The following is a description of a gene set: part of: Metabolism of vitamins and cofactors studied in species Homo sapiens Vitamins A, D, E, and K are classified as fat-soluble. Metabolic pathways by which dietary precursors of vitamins A and K are converted to active forms are annotated here. The conversion of 7-dehydrocholesterol is converted to active vitamin D is annotated as part of metabolism of steroids. (Vitamin E (tocopherol) is available in active form from the diet.) Reactome Pathway: Metabolism of fat-soluble vitamins, and this is the list of marker genes: RBP1, RBP4, APOC3, GPIHBP1, TTR, AGRN, UBIAD1, SDC3, APOB, LRP10, GPC1, PNLIP, SDC2, LRP12, LRP1, APOM (apolipoprotein M), APOE, RBP2 (retinol binding protein 2), AKR1C4, LRAT, RETSAT, GPC5, AKR1C3, LRP2, RDH11, PLB1, LRP8, GPC2, HSPG2, SDC1, APOA2, APOA1, AKR1C1, GPC6, GPC4, CLPS, APOA4, BCO1, GPC3, TTPA, LPL, VKORC1, AKR1B10, LDLR, BCO2, APOC2, VKORC1L1, SDC4